The following is a description of a gene set: Human Gene Set: KEGG_MEDICUS_REFERENCE_EGF_EGFR_RAS_PI3K_SIGNALING_PATHWAY EGF-EGFR-RAS-PI3K signaling pathway. Pathway ID: N00030. Pathway type: Reference. Pathway class: nt06260 Colorectal cancer. Pathway Definition from KEGG: EGF -> EGFR -> GRB2 -> SOS -> RAS -> PI3K -> PIP3 -> AKT -| BAD species: Homo sapiens, and this is the list of marker genes: BAD, SOS2, AKT2, SOS1, EGF, PIK3CA, HRAS (NCBI Gene Id 338029), EGFR, AKT3, PIK3CB, KRAS, NRAS, GRB2, PIK3CD, AKT1